Given this list of marker genes Sptbn4, Sptbn2, Sptb (NCBI Gene Id 383567), Spta1, Sptbn1, Prkcb, here is a description of the gene set: Mouse Gene Set: GOCC_SPECTRIN Membrane associated dimeric protein (240 and 220 kDa) of erythrocytes. Forms a complex with ankyrin, actin and probably other components of the membrane cytoskeleton, so that there is a mesh of proteins underlying the plasma membrane, potentially restricting the lateral mobility of integral proteins. species: Mus musculus